The following is a description of a gene set: Signaling by NTRK3 (TRKC) studied in species Homo sapiens Human Gene Set: REACTOME_SIGNALING_BY_NTRK3_TRKC, and this is the list of marker genes: PIK3CA, BAX, PTPRO, SRC, GRB2, NELFB, IRS1, NTF3, PIK3R1, NRAS, SHC1, PTPRS, PLCG1, KRAS, NTRK3, HRAS, SOS1